Given this list of marker genes CRIPTO, SESN1, USP53, RAPGEF6, RNF167, EPHX1, ZMYM2, IFNGR2, AFP, ITK, ZBTB20, NOP14, POU2F1, SSBP2, SCML4, KIZ, ARHGAP35, NOP16, TREML2, SIDT1, CARNS1, ADCY6, CD55, FAM3C, PELI1, NBEAL1, ACYP1, NOMO1, NSG2, PLEKHA1, EML5, TET1, MSL3B, SON, PAN3, IFT80, GRAP2, SPACA1, TTC3, RAPGEF4, ZNRF1, ANGPTL1, ITGAE, POLI, ANKRD55, RAB3IP, GRIA3, METTL8, SSH2, ID3, IL6ST, BTLA, FAM78A, TLR1, FOXO1, CD72, TIMP2, TCF7, ACTN1, GPATCH4, STAMBPL1 (STAM binding protein like 1), TNFSF8 (NCBI Gene Id 944), DPH5, RNF122, INSR, DZIP1, TSEN2, ICE2, CYLD, NEDD4L, RGS10 (NCBI Gene Id 6001), SLC6A19, TNIK, USP28, SLC25A36 (solute carrier family 25 member 36), PDK1, RALGPS2, PARP6, LCLAT1, DDC, TAGAP, INPP4B, CCND2 (NCBI Gene Id 894), ABCD3, HDAC7, RPL30, MTR, SLC11A2, BCOR, TASOR2, LEF1, SLC49A4, PDE4B, QSER1, LRCH3, USP24, FOXK1, MYC, FOCAD, ZEB1, APPL2 (NCBI Gene Id 55198), IFT25, DCAF6, TOMM34, CUX1, MDC1, TCOF1, HIPK2, ELMO3, BAZ2B, GNL1, EXOSC10, RREB1, RRAS2, DAPL1, POLR1G, MICU3, QTRT1, ELOVL5, ARV1, RGP1, IPCEF1, TDRKH, ETS2, ST6GAL1, DMXL1, ADGRG5, ISOC1, GAR1, SIPA1L1, RPP40, KLHDC2, SLC12A7, TNRC6C, ATP11C, LRRC1, CCR7, KLHDC1, TTC28, POGZ, CNGA1, PATJ, RPL36A, CYP2R1, PIM2, PRMT3, F2RL1, KBTBD11 (kelch repeat and BTB domain containing 11), ABCG1, SLC16A5, NUMB, RWDD3, CD2AP, PACSIN1, CREBL2, PALS1, SH3PXD2A, CHST15, SH3BP5, PHTF2, MGA, LDLRAP1, CCR9, ABTB3, PIK3C2A, FOXP1, MDN1, ABCA1, FYTTD1 (NCBI Gene Id 84248), TRAT1, MGST2, PCGF6, NEU3, XKRX, ITM2A, here is a description of the gene set: Human Gene Set: GSE14699_NAIVE_VS_ACT_CD8_TCELL_DN Genes down-regulated in CD8 T cells: naïve versus activated. Peripheral tolerance induction is critical for the maintenance of self-tolerance and can be mediated by immunoregulatory T cells or by direct induction of T cell anergy or deletion. While the molecular processes underlying anergy have been extensively studied, little is known about the molecular basis for peripheral T cell deletion. Here, we determined the gene expression signature of peripheral CD8+ T cells undergoing deletional tolerance, relative to those undergoing immunogenic priming or lymphopenia-induced proliferation. From these data, we report the first detailed molecular signature of cells undergoing deletion. Consistent with defective cytolysis, these cells exhibited deficiencies in granzyme up-regulation. Furthermore, they showed antigen-driven Bcl-2 down-regulation and early up-regulation of the pro-apoptotic protein Bim, consistent with the requirement of this BH3-only protein for peripheral T cell deletion. Bim up-regulation was paralleled by defective IL-7Ra chain re-expression, suggesting that Bim-dependent death may be triggered by loss of IL-7/IL-7R signaling. Finally, we observed parallels in molecular signatures between deletion and anergy suggesting that these tolerance pathways may not be as molecularly distinct as previously surmised. from publication Parish IA, Rao S, Smyth GK, Juelich T, Denyer GS, Davey GM, Strasser A, Heath WR (PMID 19204323) species: Homo sapiens